The following is a description of a gene set: Any process that activates or increases the frequency, rate or extent of DNA catabolic process. species: Mus musculus Mouse Gene Set: GOBP_POSITIVE_REGULATION_OF_DNA_CATABOLIC_PROCESS, and this is the list of marker genes: Bax, Il6, Endog, Hsf1, Igfbp3, Atm, Gata5